Given this list of marker genes IGFBP3, APLN, IL10, CDKN1A, APOE, PTGIR, MIR143, MIR15A, AIF1, MIR339, EFEMP2, MIR185 (microRNA 185), NDRG2, PTEN, MIR96, IGFBP5, IL12A, MIR1298, BMP2, MIR133A1, PPARD, GPER1, MIR140, MIR503, IL12B, ACE2, KLF4, ANG, CDKN1B, MIR4632, RBM10, APOD, NOS3 (nitric oxide synthase 3), MIR424, HMOX1, TAFA5, NDRG4, MIR145, CNN1, RGS5, MIR223 (NCBI Gene Id 407008), MIR362, TPM1, SF1, NPR1, MIR34A, GNA12, MIR182, BMP4, TGFB3, OGN, MEF2C, SOD2, PPARGC1A, MYOCD, MFN2, PRKG1, TRIB1, MIR1-1, MIR137, MIR214, ADIPOQ, MIR665, TNFAIP3, CTNNBIP1, PDCD4, PPARG, MIR638, IFNG, GSTP1, BMPR2, here is a description of the gene set: Any process that stops, prevents or reduces the rate or extent of smooth muscle cell proliferation. Human Gene Set: GOBP_NEGATIVE_REGULATION_OF_SMOOTH_MUSCLE_CELL_PROLIFERATION species: Homo sapiens